Given this list of marker genes LMOD2, HMBOX1, COL20A1, SAR1A, HRC, COX19, GBA1, IL17A, TRBV4-1, TMEM248, S100A8, SNHG3, GALK1, PDXDC1, SMIM11, CCDC38, PDCD5, PGAM1, SPNS3, SPC24, SCN1B, CACNA1E, ID1, LYPD2, QDPR, GABARAPL2, CALML5, IL36A, IFITM3, NEK4, MGAT1, SFPQ, PFKL, S100A9, CALCOCO1, UCK2, SARAF, HOMER3, LDHA, ENG, MRPL19, PRG3, ESD, INAVA, PGK1, HAMP, LTB4R, ART5, DYNLT2B, SFN, LHX3, ACAN, LY6E, RNASE2, VPS37A, CACYBP, LCE3B, SPAG5, CMPK2, SLPI, SDR9C7, TUBA8, TMEM65 (NCBI Gene Id 286052), DYNLL1, KLK9, HBE1, GDF5, H2AZ1, YWHAB, SUCLG2, GCLM, FTL, BBLN, IDE, BZW1 (NCBI Gene Id 9689), ACOT9, ACAD9, SPIC, GSTA1, RUBCN, S100A11, RAB5IF, FABP4, FAM162A, MCAM (melanoma cell adhesion molecule), RPS3A, CSTA, PTPRCAP, ATP6V0D1, SERPINB4, LGALS2, MAP6, SPRR2A (NCBI Gene Id 6700), TRAF2, PLEKHA4, PPIC, ENAH, CX3CL1, RPTN, RHOH, APP, KPRP, NHP2, RYR1, CENPC, AXL (NCBI Gene Id 558), SLC35B1 (solute carrier family 35 member B1), NFE2L2, WFDC2, BHLHE22, SNHG9, KLK6, ARG1, TP73, PRRC1, TCTE1, STX16 (syntaxin 16), PDS5B, SIGLEC5, HEXA, CHPT1, CAMK4, ACTL6B, KRTAP6-1, SSU72, NCL, RPL39, LRIF1, EIF5A, HSPD1, EXT2 (exostosin glycosyltransferase 2), SRM, AFF3, UBE2C, TNFRSF25, LIF, CHI3L1, ARMC9, CHST11, FES, TRPC6, RPS6KA4, CAPN2, RBM12, JAG1, DRD5, TCP1, PMEPA1, SRSF1, TGFA, LRRC58, GPR15LG, TXN, IL1B, CA3, CEACAM21, COX5B, ELAVL1, CHKA, WDR70, EEF1D, ENO1, HBS1L, SELENOT, EEF1B2, here is a description of the gene set: Human Gene Set: DARWICHE_PAPILLOMA_RISK_LOW_UP Genes up-regulated during skin tumor progression from low risk papilloma vs normal skin. Chemical induction of squamous tumors in the mouse skin induces multiple benign papillomas: high-frequency terminally benign low-risk papillomas and low-frequency high-risk papillomas, the putative precursor lesions to squamous cell carcinoma (SCC). We have compared the gene expression profile of twenty different early low- and high-risk papillomas with normal skin and SCC. Unsupervised clustering of 514 differentially expressed genes (P<0.001) showed that 9/10 high-risk papillomas clustered with SCC, while 1/10 clustered with low-risk papillomas, and this correlated with keratin markers of tumor progression. Prediction analysis for microarrays (PAM) identified genes that distinguished the two papilloma classes, and a majority of these had a similar expression pattern in both high-risk papillomas and SCC. Additional classifier algorithms generated a gene list that correctly classified unknown benign tumors as low- or high-risk concordant with promotion protocol and keratin profiling. Reduced expression of immune function genes characterized the high-risk papillomas and SCC. Immunohistochemistry confirmed reduced T-cell number in high-risk papillomas, suggesting that reduced adaptive immunity defines papillomas that progress to SCC. These results demonstrate that murine premalignant lesions can be segregated into subgroups by gene expression patterns that correlate with risk for malignant conversion, and suggest a paradigm for generating diagnostic biomarkers for human premalignant lesions with unknown individual risk for malignant conversion. species: Mus musculus from publication Darwiche N, Ryscavage A, Perez-Lorenzo R, Wright L, Bae DS, Hennings H, Yuspa SH, Glick AB (PMID 17525749)